The following is a description of a gene set: Genes up-regulated through activation of mTORC1 complex. species: Homo sapiens from publication Liberzon A, Birger C, Thorvaldsdóttir H, Ghandi M, Mesirov JP, Tamayo P (PMID 26771021) Human Gene Set: HALLMARK_MTORC1_SIGNALING, and this is the list of marker genes: MLLT11, CTH, SEC11A, CD9, ETF1, PSMC2 (NCBI Gene Id 5701), CDKN1A (cyclin dependent kinase inhibitor 1A), ME1, TBK1, SYTL2, PLOD2, PGM1, PSME3, ASNS, ACTR3, SLA, GOT1, NFKBIB, SLC6A6, DAPP1, SDF2L1, G6PD, IFI30, ENO1, DHFR, SLC2A1, PFKL, RRM2, GLA, HSPE1, ADIPOR2, RPA1, CYP51A1, QDPR, XBP1, GAPDH (glyceraldehyde-3-phosphate dehydrogenase), NMT1, CANX, BCAT1, RPN1, NIBAN1, ITGB2, RAB1A, FKBP2, EEF1E1, STARD4, ALDOA, PRDX1, NFIL3, HSPA4, PDK1, PSMD13 (proteasome 26S subunit, non-ATPase 13), ACLY, PPP1R15A, PSMC4, TPI1, HMGCS1, ARPC5L, ABCF2, IFRD1, GPI, IDH1, CXCR4, CDC25A, NUPR1, HK2, BTG2, USO1, HPRT1, PSMD14, GGA2, SQLE, ERO1A, CFP (complement factor properdin), RIT1, MCM2, SLC1A4, GMPS, PNP, EDEM1, SLC1A5, GSK3B, LTA4H, P4HA1, BHLHE40, TUBG1, SCD, SERP1, FADS1, UCHL5, EBP, PPA1, TMEM97, DDIT4 (NCBI Gene Id 54541), TM7SF2, DHCR7, COPS5, PSMB5, BUB1, YKT6, PITPNB, PNO1 (partner of NOB1 homolog), ELOVL6, EGLN3, CTSC (cathepsin C), ADD3, SORD, LDHA, ELOVL5, DDX39A, NUFIP1, SLC7A11, STC1, TCEA1, CACYBP, PSMD12, FGL2, SHMT2, ACACA, MTHFD2, PSMA3, UNG, AK4, CYB5B, PIK3R3, CALR, EPRS1, PLK1, SRD5A1, DDIT3, GBE1, IDI1, UBE2D3, ATP6V1D, GTF2H1 (NCBI Gene Id 2965), SERPINH1, GLRX, SC5D, PSPH, SSR1, SLC7A5, PSMA4, SQSTM1, TES, STIP1, EIF2S2, AURKA, HMGCR, PSMG1, GCLC, NUP205, PSAT1, MAP2K3, CCNG1, PSMC6, POLR3G, SLC37A4, TUBA4A, VLDLR, TRIB3, PHGDH, CCT6A, CORO1A, FADS2, FDXR, LDLR, SLC2A3, RDH11, HSPA5, PGK1, MCM4, LGMN, CCNF, DHCR24, SKAP2, ATP2A2, NHERF1, MTHFD2L, HMBS, NFYC, NAMPT, INSIG1, ACTR2, IMMT, PDAP1, TFRC, HSP90B1, RRP9, IGFBP5 (NCBI Gene Id 3488), HSPD1 (heat shock protein family D (Hsp60) member 1), ATP5MC1, UFM1, ACSL3, M6PR, PPIA, HSPA9, TOMM40, WARS1, TXNRD1, GSR